The following is a description of a gene set: Human Gene Set: GSE37301_LYMPHOID_PRIMED_MPP_VS_COMMON_LYMPHOID_PROGENITOR_DN Expression profiling of Rag2-deficient Ets1++ and Rag2-deficient Ets1-- mature NK cells and WT bone marrow progenitors, WT T cells, and WT Pro B cells studied in species Homo sapiens from publication Ramirez K, Chandler KJ, Spaulding C, Zandi S, Sigvardsson M, Graves BJ, Kee BL (PMID 22608498) Genes down-regulated in lymphoid primed multipotent progenitors versus common lymphoid progenitors., and this is the list of marker genes: EIF2B2, TMEM40, CRKL, CPSF7, ADRA2C, SEC14L1, IQGAP2, OGFR, HMGA1, RNF19B, ALOX12, MYD88, CRLF3, ATP1B3, LGMN, KRT20, TRIM25, RAB3IP, HIPK2, NIP7, SSTR5, TPD52, TRNT1, PKM, TNKS1BP1, NOP58, GRINA, MED12L, NTPCR, CASP8AP2, GLG1, PLSCR1, MSH2, CCNL2, SMIM1, MYO10, PDK3, UCK2 (NCBI Gene Id 7371), NEFH (NCBI Gene Id 4744), AMPD3, GPR3, ARHGDIG, PTPRCAP, ZNF131, UBA7, LSM14A, WDR26, HMGCR, CDC25C, SRGN, MX2, BTG1, SLPI, JAK2, OTUD5, BCL6B, MTHFD2, TSEN15, ABRACL, ANKFY1, REN, TCF25, ZNFX1, ISG20, GNL3, LY6E, CHMP4B, JUND, ID3, KRT25, RPS6KA3, FXYD5, PGM2 (phosphoglucomutase 2), MRPL42, SLC1A4, TINF2, NRGN, ATP5MC2, EZR, YTHDC1, SOD2, SEMA3A, PTN (pleiotrophin), AZIN1, ATAD1, PTPRM, SAMD4B, EPS8, AFG2A (NCBI Gene Id 170576), CCDC86, MARK2, BTBD17, USP7, CCL7, COL13A1, RPAP3, YTHDF1, CAMLG, PLEKHA7 (pleckstrin homology domain containing A7), COX17 (cytochrome c oxidase copper chaperone COX17), ANPEP, ETF1, PHC2, EXT1, IL1RN, CD14, ESR1, REEP1, ZNF639, IL13RA1, RBX1, PTPN2, PLGRKT, KLF2, SELPLG (NCBI Gene Id 6404), INPP1, FLOT1, APMAP, GATM, GBP2, TYR, NIPBL, CYB561, ELF1, TCEAL9 (NCBI Gene Id 51186), DCK, CGA, KRT15, GADD45B, ARIH1, ADPRH, CHFR, IGFBP1 (NCBI Gene Id 3484), LGALS3BP, ARPC3, RXRG, ITGA3, RNPEP, MAP3K6, RPS27L, MBD2 (methyl-CpG binding domain protein 2), SATB1, CCR5, USP18, HMOX1 (heme oxygenase 1), C5orf15, CMTR2, ENC1, TRIM47, PCGF5, APOA5, METTL9, CSNK2A2, RASD1, SMARCA5, NXT1, ATG16L1, SAMHD1, TUT7, ARSA, SPPL3, THBD, UBAP2L, HOXC5, MPG, SMARCC1, MAF, ARPC2, IFIH1, NUP188 (nucleoporin 188), ZZZ3, GNAI2, NPM1, IL15, NUPR1, FUS (FUS RNA binding protein), MBTD1, ATP6V1A, LMO4, SGK1, TCIRG1, GNA14, MYCBP2, DNTTIP2, IFIT3, PUS1, WDR43, CTNNA1, XDH, CRAMP1, INHBB, TRA2B, CCNG1, SPIC, CEBPD, RAB12, ADIPOQ, BRD8, CCL2, CMPK2